The following is a description of a gene set: Maternal transcripts are transcribed from the maternal genome and accumulate in the oocyte during oogenesis. A subset of these maternal transcripts is degraded during later development of the unfertilized oocyte and after fertilization of the oocyte. Maternal decay of maternal transcripts (M-decay, reviewed in Jian and Fan 2022) refers to the degradation of maternal transcripts by maternally provided factors such as ZFP36L2 (inferred from the mouse homolog in Chousal et al. 2018, Sha et al. 2018), BTG4 (inferred from the mouse homolog in Liu et al. 2016, Yu et al. 2016, Pasternak et al. 2016, Zhao et al. 2020), and AGO2 (inferred from the mouse homolog in Zhang et al. 2020). ZFP36L2 acting before fertilization and BTG4 acting after fertilization recruit the CCR4-NOT deadenylation complex to the mRNA to initiate degradation. AGO2 is primed with endogenous small interfering RNAs (endosiRNAs) produced from double-stranded RNAs that originate from specific loci. The resulting AGO2:endosiRNA complexes bind and hydrolyze complementary maternal mRNAs. Similar patterns of mRNA decay are observed in human and mouse zygotes. part of: Maternal to zygotic transition (MZT) Reactome Pathway: M-decay: degradation of maternal mRNAs by maternally stored factors studied in species Homo sapiens, and this is the list of marker genes: FGF8, PABPC1, CNOT3, KPNA2, KDM1B, CNOT4, EIF4A2, PADI6, ELL2, CNOT7, TET2, CNOT8, PAIP2, BIRC5, CNOT6, NOBOX, CPEB1, KDM4C, AGO2, CNOT11, CNOT1, TUBB4B, RPS2, MED13, TNKS1BP1, DICER1, BTG4, EIF4A3, CNOT9, EIF4A1, ZFP36L2, ELOC, ZP2, MED12L, EIF4E, PABPN1L, EIF4G1, KDM5A, KDM4B, KDM5B, PAIP1, POLR2D, CNOT2, CNOT6L, EIF4B, CNOT10